The following is a description of a gene set: Human Gene Set: HP_ABNORMAL_TOTAL_HEMOLYTIC_COMPLEMENT_ACTIVITY Any deviation from the normal total hemolytic complement activity in the circulation. Abnormal total hemolytic complement activity species: Homo sapiens, and this is the list of marker genes: SERPING1, C4A, C5, C1QB (NCBI Gene Id 713), C6